Given this list of marker genes Asrgl1, Pah, Pcbd1, Qdpr, Kyat1, Il4i1, here is a description of the gene set: Phenylalanine metabolism species: Mus musculus Mouse Gene Set: REACTOME_PHENYLALANINE_METABOLISM